Given this list of marker genes Bag1, Rock1, Zpr1, Crlf1, Map3k12, Nefl, Clcf1, Map2k4, Bcl2, Rhoa, Cntfr, Vps54, Erbb3, here is a description of the gene set: Mouse Gene Set: GOBP_NEGATIVE_REGULATION_OF_MOTOR_NEURON_APOPTOTIC_PROCESS species: Mus musculus Any process that stops, prevents or reduces the frequency, rate or extent of motor neuron apoptotic process.